Given this list of marker genes GABRB3, NPAS4, INSYN1, NTSR1, DRD4, ADORA2A, UNC13B, CHRNA2, NLGN2, INSYN2A, ABAT, NLGN3, GRIK2, GLRA1, RIMS1, RIMS2, CHRNA4, here is a description of the gene set: species: Homo sapiens A process that causes a temporary decrease in postsynaptic membrane potential due to the flow of negatively charged ions into the postsynaptic cell. The flow of ions that causes an IPSP is an inhibitory postsynaptic current (IPSC) and makes it more difficult for the neuron to fire an action potential. Human Gene Set: GOBP_INHIBITORY_POSTSYNAPTIC_POTENTIAL